The following is a description of a gene set: from publication Chen Y, Wang X (PMID 31504780) Human Gene Set: MIR634 species: Homo sapiens Genes predicted to be targets of miRBase v22 microRNA hsa-miR-634 in miRDB v6.0 with MirTarget v4 prediction scores > 80 (high confidence targets)., and this is the list of marker genes: ARPC1B, VASN, PDCD6IP, MRPS16, MPP7, CLCN6, IGDCC4, ZDHHC22, ATP2A2, EEA1, BLOC1S5, MAP3K2, DENND2B, RAB11A, USP10, KLB, TBCA, MAPK1IP1L, C2orf49, FAM168B, CERK (NCBI Gene Id 64781), PPP4R1, SCGN, CKS1B, FURIN, SLCO2B1, RICTOR, AAMP, FBXW7, AADACL3, PDIK1L, ANKRD40, CLIC5, CPEB3, TTC28, NPR2, EIF3J, RAB1A, SAMD4A, A1CF, CTDSP2 (NCBI Gene Id 51589), ARPP21, IRX2, UACA (NCBI Gene Id 55075), HMGN1, SLC8B1, NRXN3, ATXN1L, VGLL4, HRK, ATXN7 (NCBI Gene Id 6314), ITGB6, DYRK1A, ADAM18, FOXP2, EIF4E, NPHP4, PTPN3, THBS1, CKMT2, ARGLU1, DLST, ATP6V0B, MSL2, PFKFB2, TBC1D8, CRISPLD2, H2AZ2, KPNA1, RADX, HS2ST1, SNRPE, MAP3K1, OAZ1, KCNK2, PHACTR1, DNM1L, MBIP, KCNB1, SLC4A8, PHIP, FAM3D, HMGXB4, PCGF3 (polycomb group ring finger 3), TIMM9, CYP2C8